Given this list of marker genes HOXB6, ANKS1B, H2AC25, MAPK10, LMF2, VPS4B, NTRK3, RFC1, NCAM1, NRDC, STK19, TBC1D15, C1orf74, CCND2, PARD6A, JUND, HPS5, ICAM5, RAB1A, NFKB2, KIF9, C4orf33, ACOX3, HSPB6, PROSER3, SLC30A5, HSPD1, COQ7, RNF44, KPTN, SPAG9, RRM1, CRHBP, MBNL2, PPARGC1A, SERTAD3, GTF3C2, CORO6, GZMB, EIF5A, DNAJC27, PKP4, HOXB3, PSKH1, DGKG, PRPF31, NKIRAS2, RPL9, CPNE1, SAP30BP, ZNF593, DEPDC4, H2AC20, NARS2, NUFIP1 (nuclear FMR1 interacting protein 1), POU2AF1, TMEM183A, ZMYM4, BCL11A, ARL8A, ABTB3, TBX2, SYT11, H2AC21, STAT3, PITX2, CBX8, WFIKKN2, CDKN1B, TNFAIP1, KLHL18, JUP, MECR, ACVR2A, JAG1, ARIH1, PELP1, FGF14, CDC42, MYH7, ORAI3, PRRC2A, RPS3, NPAS4, C1QTNF7, RING1, CRK, OARD1, ZC3H18, DIO3, FCF1, ABCE1, JADE2, ARID4B, RBM15B, HOXD11, RFX5, GSC, CCND1, SREBF2, THOC1, CHD2 (NCBI Gene Id 283680), DCTN1, ESRRG, PRRC2C (NCBI Gene Id 23215), GGPS1, HOXC10, RBP5, STX4, CLSTN3, SLC38A4, NAT10, ARID4A, ZNF576, GTF2H1, DPH3, AP1G1, JMJD1C, ODR4, NOL4, MAPKAPK5, DNAJC7, GPALPP1, MEIS2, TRPC1, E4F1, PAX3, NCAPH2, SLC25A3, PIP4K2A, RBKS, DENND5A, CACNA1G, CDKN2C, ING4, HOXC11, DUSP1, NIN, CMSS1, ZFAND2B, IFT20, SNF8, H2BC21, OXNAD1, HOXB5, NUBPL, PAX7 (NCBI Gene Id 5081), SCLT1, COX8A, CTNND2, FDXR, DNM3, AP2B1, ISG20, SPRY2, HOXC4, ERBB4, PHACTR3, USP14, GPAM, AREL1, SYT12, FEZ1, RAP1GDS1, EHD4, SH2D2A, XPR1 (xenotropic and polytropic retrovirus receptor 1), SEC24D, SMPD4, HMOX1, PLCD3, DHX40, TRIM27, TRMT10A, ENSG00000255537, MAP3K11 (NCBI Gene Id 4296), AFF4, ADO, EFHD1, CCDC140, TGFB3, LIN54, PAK1, ATP6V0E1, TLK1, PSMB2, SRSF6, SMARCAD1, IFT52, SCFD2, PRICKLE1, IRX4, MITF, ANKH, NUP155, TMEM33, ICE2, VPS37B, TFPT, LRP1B, RECQL5, MED15, ETV5, UBE2B, ELF5, MAPKAPK5-AS1, ZGRF1, PPP4R3A, USP48, CELF6 (CUGBP Elav-like family member 6), DXO, SHISA6, CSRP2 (cysteine and glycine rich protein 2), TMEM39A, ESM1 (NCBI Gene Id 11082), NOL10, ATP8B2, PRDM10, MBIP, COL3A1, TPR (NCBI Gene Id 7175), KLHL12, RNPS1, BRMS1, GPR155, CWC25, GRK6, PHLPP1, ANAPC10, EBF1, SPRED2, HNRNPAB, USP36, ALS2, IWS1, RIPOR1 (RHO family interacting cell polarization regulator 1), PACSIN3, JADE1, RALGAPA1P1, MZT2B, PHF21A, YTHDC2, FBXW9, DIO2, NOLC1 (nucleolar and coiled-body phosphoprotein 1), SHANK2, HSPE1, H2BC26, POGZ, ZNF2, RAB25, ZNF687, LIAS, BABAM2, HTN1, here is a description of the gene set: Genes having at least one occurrence of the motif CGTCAN in the regions spanning 4 kb centered on their transcription starting sites. This matches the CREB1 transcription factor binding site V$CREB_Q3 (v7.4 TRANSFAC). Human Gene Set: CREB_Q3 studied in species Homo sapiens